The following is a description of a gene set: Catalysis of the hydrolysis of a carboxylic ester bond. species: Mus musculus Mouse Gene Set: GOMF_CARBOXYLIC_ESTER_HYDROLASE_ACTIVITY, and this is the list of marker genes: Acot11, Acot7, Pla2g2e, Prdx6b, H6pd, Lipe, Abhd6, Lipc, Ddhd2, Ces2g, Aadac, Pla2g4c, Ces2h, Ces4a, Lipo3, Gm8978, Ndst2, Rpe65, Aldh2, Pafah2, Pla2g5, Dph7, Lpl, Apoh, Ptrh1, Pla2g2a, Acot9, Ces3b (NCBI Gene Id 13909), Esd (esterase D/formylglutathione hydrolase), Gde1, Pnpla3, Ppt1, Ddhd1, Gdpd3, Oc90, Plaa, Pgls, Ces5a, Lipf, Prdx6, Lipo1, Abhd15, Anxa2, Ces1d, Lipn, Cel, Scgb1a1, Apmap, Abhd11, Pla1a, Abhd8, Pnpla7, Ache, Apoa5, Pla2g4d, Acot12, Abhd16a, Ces2b, Pnpla2, Gpihbp1, Ces1a, Pla2g4f, Etf1, Ces1f, Pla2g4a (NCBI Gene Id 226493), Mgll, Pla2g2f, Pafah1b2, Dtd1, Dagla, Pla2g15, Lipg, Casp3, Ptrh2, Ndst3, Abhd1, Lypla1 (NCBI Gene Id 18777), Baat, Acot2, Gdpd1, Plaat5, Ces2f, Abhd10 (abhydrolase domain containing 10), Aadacl3, Abhd16b, Abhd2, Pafah1b3, Ces1c, Acot1, Ldah, Apoc2l, Enpp2, Faah, Lcat, Pnpla6, Pnlip, Macrod1, Ptrhd1, Pon2, Daglb, Pla2g1b, Alkbh5, Pla2g2d, Pgap6, Rgn, Liph, Apoc2, Pgap1, Plaat3, Aspg, Ppme1, Chka, Pon1, Ces1b, Oard1 (O-acyl-ADP-ribose deacylase 1), Notum, Lipa, Tnfaip6, Ces1e, Pnliprp1 (pancreatic lipase related protein 1), Nceh1, Acot5, Pon3 (paraoxonase 3), Pnpla8 (NCBI Gene Id 67452), Lypla2, Ces2e, Pnliprp2, Siae, Abhd12b, Bphl, Macrod2 (NCBI Gene Id 73752), Ces3a, Pla2g7, Car2, Pnpla1, Abhd5, Bche, Pla2g12a, Ces2c, Car1, Abhd3, Ndst1 (N-deacetylase/N-sulfotransferase (heparan glucosaminyl) 1), Anxa3, Pla2g3, Proca1, Aoah, Lipo4 (lipase, member O4), Dtd2, Pnpla5, Acot10, Acot6, Pla2g6, Ces2a, Mrpl58, Adprs, Ces1g, Pla2g10, Acot8, Plaat1, Lipo2, Abhd4, Ces1h, Acot3 (NCBI Gene Id 171281), Pla2g2c, Pla2g4b, Anxa1, Pla2g12b (NCBI Gene Id 69836), Pla2g4e (phospholipase A2, group IVE), Plb1, Lyplal1, Abhd12, Acot4